Given this list of marker genes Ccng1, Cdk5r1, Cdk6, Cdkl2, Ccnd2, Ccno, Mnat1, Cdk18, Ccnq, Ccnh, Cdk3, Cdkn2c, Cdkn1b, Ccnc, Ccnd1, Ccnd3, Cdk9, Cdk7, Ccne1, Ccnb1, Ccny, Cdk16, Ccng2, Ccnf, Cdk2, Tex24, Cdkn1a, Cdkn2d, Cdk11b, Cnppd1, Ccnjl, Cdkl3, Ccnb1-ps, Cdk10 (NCBI Gene Id 234854), Cdk5r2, Ccni, Ccnj, Ccna1, Ccna2, Mok, Cdkl4, Cdkn2b, Hexim1, Ccnb3, Inca1, Cdkl1, Ccnb2, Casp3, Kat2b, Cdk15, Hexim2, Cdk12, Cdk5, Cdk19, Ankrd42, Cdk1, Cdk4, Ccne2, Ccnl2, Cdk20, Cdkl5, Cdk13, Ccnt2 (cyclin T2), Cks2, Cdkn2a (NCBI Gene Id 18560), Ccnk, Cks1b, Cdkn1c, Ccnt1, Ccnl1, Cdk17, Cdk8, Cks1brt, Cdk14, here is a description of the gene set: species: Mus musculus Mouse Gene Set: GOMF_CYCLIN_DEPENDENT_PROTEIN_KINASE_ACTIVITY Cyclin-dependent catalysis of the phosphorylation of an amino acid residue in a protein, usually according to the reaction: a protein + ATP = a phosphoprotein + ADP.